Given this list of marker genes H2bc11, H2ac23, H2az2, H2ac24, H2ax, H2ac20, H4c1, H4c6 (H4 clustered histone 6), H2ac11, H2ac6, H2bc27 (H2B clustered histone 27), H3c6, H2ac8, Kdm6a, H3c10, H2ac10, H2ac1, H2ac19, H2bc12, H3c7 (NCBI Gene Id 260423), Ash2l, H2bc7, H3c4, H2bc15, H2bc3, H4c8, H2bc1, H3c8, H2ac13, H2bc9, Pparg, H2bc8, Hdac3, H4c14, Paxip1, H4c18, H2ac22, H4c17, H4c4, H3c15, H2bc22, H3c1, H2ac15, H3c3, H4c3, H3c11, H4c12, H3f3a, Ncor2, H2ac12, H3c13, H2ac4, H2bc13 (NCBI Gene Id 319185), H4c2, Gps2 (G protein pathway suppressor 2), H3c2, H4c11, H4c9, H2ac7, Tbl1x (transducin (beta)-like 1 X-linked), here is a description of the gene set: This event has been computationally inferred from an event that has been demonstrated in another species.<p>The inference is based on the homology mapping from PANTHER. Briefly, reactions for which all involved PhysicalEntities (in input, output and catalyst) have a mapped orthologue/paralogue (for complexes at least 75% of components must have a mapping) are inferred to the other species. electronically inferred by orthology from the curated human pathway studied in species Mus musculus Reactome Pathway: Epigenetic regulation of gene expression by MLL3 and MLL4 complexes part of: Epigenetic regulation by WDR5-containing histone modifying complexes